Given this list of marker genes FBXW11, FGD1, ANKDD1A, TNPO1, NAT1, PPM1D, CNN3, MTNAP1, JMJD1C, GPAM, PDE5A, DTNA, PPTC7, FBXW8, KNTC1, ARL4C, NR2C1, RORA, UNC80, KANSL1, FAM221A, SKIL, ARHGAP32, CNTLN, THUMPD1, ZZZ3, MED13 (mediator complex subunit 13), ADAM22, CPNE3, SPIDR, C5orf24, ATAD5, USP42, B3GAT1, DPPA3, RIMKLB, ZMYND19, RAB14, BCL11A, TMEM170B, ARID2, SNAI1 (NCBI Gene Id 6615), PLSCR5, SVIL, KLHL15, WDR47, B3GLCT, TDRD6, ZNF292, ZNF473, ZNF492, WAPL, ZFX, CALB1, KMT2D, ZNF627, PIK3R1, SDR16C5, NUTF2, TNRC18, SCML2, PICALM, QKI, MTPN, TSC22D2, MIA2, ZNF516, RBM7, ZFHX4, ZNF281, RETREG1, VEPH1, SELENOT, ACTR10, PHIP, COTL1, ROBO2, CD1E, MAN1C1, RNF212B, TAF5, ASAP1, STK4, TUBB1, ONECUT2, ETV5, PTPN2, PPFIA2, ZFP36L1, HERC4, ETV1, WTAP, RNF13, DSC3, LZTFL1, HNRNPH1, RNF14, VKORC1L1, LRRC19, CEP85L, ANKRD12, FNDC3A, FERMT2, C1orf141, SFTPA2, PAPPA, DUSP9, POGZ, ACTC1, CDC42BPA (NCBI Gene Id 9876), BRWD1, PARP16, SOCS6, RNF111, MAPK8, RAD17, NTN4, TRAM2, PCBP4, SOCS5, NRBF2, TRUB1, ZNF124, SLC35F3 (solute carrier family 35 member F3), MFSD1, RAB9B, DDX46, PROM1, KBTBD8, DNMT3A, MACO1, FBXL3, ALG2, SPEN, ZNF598, RNF2, RTKN2, TOP2B, MIER3, GPC4, TPBG, EEA1 (NCBI Gene Id 8411), TBC1D12, TNFSF13B, CPSF6, SOX15, SRSF1, PIK3R3, ZFC3H1, ZNF713, VAMP7, UBA6, ARHGAP21, SMG1, LMBRD2, RLIM, GSDME, RELL1, SETBP1, GCC2, CUL5, MTMR4, DCK, KIF5B, MON2, FBXO11, NFAT5, INO80D, RGS5 (regulator of G protein signaling 5), UGGT1, MICU3, TASOR, SLITRK6, USP48, GMFB, ELMOD2, GRM7, UNC5C, CDYL, LRRC4C, ZBTB5, GJC1, KIF3A, GALNT7 (NCBI Gene Id 51809), PALM2AKAP2, GTF2A1 (NCBI Gene Id 50857), FABP7, DMTF1, KRCC1, SON (SON DNA and RNA binding protein), MSL2, TAPT1, PCDH19, WDR26, ATF1, BRWD3, ERMP1 (NCBI Gene Id 79956), MBP, MTFR1, TMC1, PLS1, CNTN4, GFM1, SAR1B, CCAR1, GABPB2, SZRD1, SS18, JPH1, LATS1, BMP3, CPNE8, CRABP2, FOXJ3, ZBTB18, PCDH7, ZNF273, EFNA5, DCC, SERINC3, CXCR4, ANKIB1, CAPRIN1, DNAJC27, CUL3, STRN, P3R3URF-PIK3R3, ARHGAP28, GPATCH1, RBMS3, SLAIN2, CDC14A, ERCC6L2, NAB1, EDNRB, BNIP3L, YPEL2, PPP3CA, here is a description of the gene set: Human Gene Set: MIR548G_3P from publication Chen Y, Wang X (PMID 31504780) species: Homo sapiens Genes predicted to be targets of miRBase v22 microRNA hsa-miR-548g-3p in miRDB v6.0 with MirTarget v4 prediction scores > 80 (high confidence targets).